Given this list of marker genes Abca3, Abca1, Plscr3, Slco2b1 (solute carrier organic anion transporter family, member 2b1), Abcg1, Atp9a, Slco1c1, Abca5, Abca15, Cidea, Slco1a1, Atp10a, Abcd2, Atp10d, Apom, Gramd1a, Stard3 (NCBI Gene Id 59045), Gltpd2, Osbpl6, Fabp4, Ceacam2, Abcg8, Slc22a2, Apoa1, Xkr8, Abcb11, Cert1, Prelid3b, Cptp (NCBI Gene Id 79554), Atg2a (NCBI Gene Id 69041), Slco4a1, Slc27a6, Npc1l1 (NCBI Gene Id 278378), Apob, Ano10, Ano1, Bltp3b, Abca4, Pitpnm3, Abcg5, Abcc1, Slco1a7, Atp8b4, Pctp, Abca8b, Rbp4, Abca16, Clptm1l, Apoa2, Ano8, Serinc2, Abcb4, Slc10a5, Cd36, Star, Npc2, Stard5, Atp8a1, Abca9, Cideb, Tmem30a, Ano6, Slc10a1, Pitpnm2, Atp11c, Abca2, Apoa5, Slc5a8, Vdac2, Abcg4, Ano9, Mfsd2a, Abcb1b, Scp2, Slco1a8, Atg2b, Abcc4, Atg9a, Slc51a, Plscr1l1 (NCBI Gene Id 78459), Slc27a5, Ano7, Tmem135, Slc22a7, Mttp, Abcd4, Fabp3, Pltp, Slco1a6, Pitpnc1, Slc22a30, Slco2a1, Pitpnb, Mfsd2b, Atg9b, Apoe, Fabp1, Slco1a4, Esyt1, Plscr5, Fabp2, Slc27a2, Ttpa, Gramd1b, Serinc3, Plekha8, Gltp, Slc22a28, Triap1, Gramd1c, Abca8a, Abca13, Slc10a4, Stard4, Abca17, Osbpl3, Slc2a1, Ceacam1, Xkr9, Bltp1, Plscr1, Slc22a19, Atp8b5, Slc10a2, Vmp1, Atp8b2, Osbpl8, Xkr4, Slc10a3, Prelid3a (PRELI domain containing 3A), Ano3, Abcd1, Slc22a29, Slc22a27, Tnfaip8l3, Pitpnm1, Atp11b (ATPase, class VI, type 11B), Atp11a, Osbpl5, Atp9b, Slc22a6, Slc22a26, Spns2, Serinc5, Apoa4, Slc22a1, Atp10b, Slc10a4-ps, Prelid2, Tmem30b, Slc51b, Abca14 (NCBI Gene Id 75158), Atp8b3, Slc25a20, Cidec, Abcd3, Slco1a5, Osbpl2, Ano4, Slc27a4, Ano2, Gm2a, Npc1, Slc22a8, Prelid1, Stra6, Slco3a1, Plscr2, Slc27a1, Slco1b2, Slc10a7, Abca6, Slc10a6, Abca12, Abcb1a, Abcc3, Plscr4, Atp8a2 (ATPase, aminophospholipid transporter-like, class I, type 8A, member 2), Osbp, C2cd2l, Stra6l, Fabp5 (fatty acid binding protein 5, epidermal), Abca7, Slc43a3 (solute carrier family 43, member 3), Tmem41b, Ano5, Atp8b1, Pitpna, here is a description of the gene set: Enables the directed movement of lipids into, out of or within a cell, or between cells. Mouse Gene Set: GOMF_LIPID_TRANSPORTER_ACTIVITY studied in species Mus musculus